Given this list of marker genes GH2, CSH2, JAK3, CSH1, SOCS2, TYK2, JAK1, GH1, JAK2, CSHL1, here is a description of the gene set: Binding to a growth hormone receptor. Human Gene Set: GOMF_GROWTH_HORMONE_RECEPTOR_BINDING studied in species Homo sapiens